Given this list of marker genes TGFB2, TGFB1, TGFBR2, TGFB3, TGFBR1, ENG, here is a description of the gene set: species: Homo sapiens Any process that modulates the frequency, rate or extent of epithelial to mesenchymal transition involved in endocardial cushion formation. Human Gene Set: GOBP_REGULATION_OF_EPITHELIAL_TO_MESENCHYMAL_TRANSITION_INVOLVED_IN_ENDOCARDIAL_CUSHION_FORMATION